The following is a description of a gene set: studied in species Mus musculus Human Gene Set: JACKSON_DNMT1_TARGETS_DN Cytosine methylation of mammalian DNA is essential for the proper epigenetic regulation of gene expression and maintenance of genomic integrity. To define the mechanism through which demethylated cells die, and to establish a paradigm for identifying genes regulated by DNA methylation, we have generated mice with a conditional allele for the maintenance DNA methyltransferase gene Dnmt1. Cre-mediated deletion of Dnmt1 causes demethylation of cultured fibroblasts and a uniform p53-dependent cell death. Mutational inactivation of Trp53 partially rescues the demethylated fibroblasts for up to five population doublings in culture. Oligonucleotide microarray analysis showed that up to 10% of genes are aberrantly expressed in demethylated fibroblasts. Our results demonstrate that loss of Dnmt1 causes cell-type-specific changes in gene expression that impinge on several pathways, including expression of imprinted genes, cell-cycle control, growth factor/receptor signal transduction and mobilization of retroelements. Genes down-regulated in MEF cells (embryonic fibroblast) upon Cre-lox knockout of DNMT1. from publication Jackson-Grusby L, Beard C, Possemato R, Tudor M, Fambrough D, Csankovszki G, Dausman J, Lee P, Wilson C, Lander E, Jaenisch R (PMID 11137995), and this is the list of marker genes: SCD, POLD1 (DNA polymerase delta 1, catalytic subunit), GJB2, HMGB1 (NCBI Gene Id 3146), GAS2, COL6A2, DNMT1, COL6A1, GRB10, U2AF2, CENPA, COL9A1, PEG3, COL11A1, MDH2, JUP, CRABP1, EFNB1, FZD8, LDLR, IGF2, H19